Given this list of marker genes RIN2, PPARD, NDP (norrin cystine knot growth factor NDP), TSPAN3, KLF10, CES1, LEPROT (NCBI Gene Id 83080), EMC7, FASTKD1, SIK3 (SIK family kinase 3), MYO15B, SGK1, EPB41L3, APOO, PLIN2, PRKRIP1, HSD11B1, MAN2A2, CDS2, CCND1, FCGR1A, AOAH, SLC7A7, SP110, SOD2, CCL3, SERPINE1, FAH, CXCL10, CLEC4E, LYSET, LPAR1, PCK2, CYP27A1, SP140L, OAZ2, PLCL2, RDX, LAIR1, SDC2, LTA4H, FYN, CDKN1C, SLC5A3, ACAA2, SLAMF8, BCAT1, LILRB2, TMEM184C, MX2, ASAH1, TBC1D16, HDAC9, PPIF, TNFAIP6, CXCL5, MPZL1, PLA2G7, C1S, CD81, CMKLR1, EIF2B3, VAT1, DAB2, CHST15, CTSD, LPXN, RBM47, NCOA4, BCAP31, SLC16A6, DDIT4, PDCD6IP, TIMP2, SEPTIN9, MPRIP, TSEN34, DUSP6, VMP1, BTN3A3, DOCK4, HLA-DQA1, NDRG1, NUP214, FTH1, PDE4DIP, FBXL5, HK2, TSC22D1, ANXA5, FPR1, ZFYVE16, CCL18, EEF1AKMT3, DECR1, GPNMB, AKR1C1 (NCBI Gene Id 9418), CD14, ME1, CD47, CXCL9, VSIG4, SC5D, SLC29A3, PDIA5, IL1B, TFEB, ACP5, SCCPDH, ADAM28, TLE4, CD9, VWA5A, MT2A (NCBI Gene Id 4502), GCLM, SLC11A2, SCO2, SLC12A8 (solute carrier family 12 member 8), TCF7L2, SUN2, MFHAS1, PTGDS, TGM2, HBEGF, RDH11, CSTF3, ST6GAL1, YIPF6, SCD, SNTB1, MDM1, SLC36A1, STAT1, GRPEL1, CRTAM, EMC2, ITGAL, ITPR1, KCNMA1, RGCC, MYD88, ZNF395, GM2A, RARRES1, ARFGAP3, PTGER2, CTSL, NDUFS2, ELOA, SLC2A3 (solute carrier family 2 member 3), PRDX1, APOC1, MT1F, ANOS1, RGL1, ENTPD1, IRAG2, FKBP4, CNPY3, DNTTIP2, DHCR24 (NCBI Gene Id 9800), HEXB, RNASET2, METTL9, HDDC2, TNS3, TBC1D1 (TBC1 domain family member 1), IDO1, S100A9, SLC3A2 (NCBI Gene Id 6520), STK17A, GNA12, SEC22B, RHOQ, PECAM1, ABCC3, DAD1, CHI3L1, ZNF804A, CLEC5A, EREG, ACAT1, HLA-DRB4, MYOF, SPTLC2, PSMB5, ATP6V0A1, CYP27B1 (cytochrome P450 family 27 subfamily B member 1), NAMPT, CTSK, RUBCNL, GSR, GTF3A, LTBP2, LHFPL2, SQSTM1, CX3CR1, PLSCR1, NQO1, GOT2 (glutamic-oxaloacetic transaminase 2), EMG1, EGR1, TLR1, GALC, S100A12, APLP2, LMO2, SELL, CFD, FBP1, TFRC, RAB20, MTX2, IQGAP2, FCN1, MSRB2, CCR1, MMP9, SPP1, GSDME, SMIM7, AKR1B1, LXN, STOM, CHPT1, CXCL1, SPHK1, AKT3, ADAMDEC1, CCDC69, ATP6V1C1, NINJ2, SLC43A3, NRIP3, NPC1, CTBS, CALHM2, TRIT1, MRPL35, MITF, ALAS1, GGH, CHPF2, CXCL3, IRAK3, PLTP, SNX10, NOTCH2 (notch receptor 2), ACP3, C1QA, NKG7, CD163, HADHA, RAP1GAP2, TM9SF4, CCL8, EIF2AK2, ALOX5, SLC1A4, PIGP, ARHGEF40, TREM1, CPD (carboxypeptidase D), UFSP2, ALDH3A2, LAMP2, AMY1A, ATP6V0E1, SLC31A1, MT1H, MT1G, CASP1, TCIRG1, NCOA1, LILRB4, KLF9, PNP, CYBB, CERT1, SLC1A3, ETS2, PID1, NARS1, FADS1, NAT1, TMX4, CNPY2, PLAAT4, CALML4, SLAMF7, CD52, NR1H3, METTL1, SCAMP2, APOE, TMEM51, PSTPIP1, FCAR, GBA1, SLC35B1, TMBIM6, DHRS4, NEDD9, DPEP2, PDXK, PLOD3, ILRUN, TCEAL9, KMO, NR4A2, ATP6V1H, IL18, ZNF706, SCARB2, PACSIN2 (NCBI Gene Id 150377), CCL2, ITPK1, DCSTAMP, IL1A, MS4A4A, CD48, MT1X (NCBI Gene Id 82523), TNK2, IFI6, TEX2, AQP9 (aquaporin 9), TUBA4A (NCBI Gene Id 93373), DMXL2, B4GALT5, HLA-E, IFITM2, SMAD3 (SMAD family member 3), FDX1 (ferredoxin 1), SLC7A11, CYP1B1, TRAF3, ATP9B, SIGIRR, C3AR1, PIR, C5AR1 (NCBI Gene Id 728), PGS1, GADD45G, PINK1, ACADVL, SDR39U1, TM6SF1, EIF2S1, PRKCB, CRIM1, MDH1, DENND3, CCR5, DNPH1, CD300A, TNIP3, PLPP3, RERE, SH3BP5, GPD2, VNN1, C3, SLC30A1, MATK, IL10, MMP2, GLA, PSMG1, CCRL2, LAMP1, ATP13A3, GNS, IGFBP7, AMPD2, RAB13 (RAB13, member RAS oncogene family), NPL, G6PC3, SGMS1, CD55, NRP1, MCTP1, PHACTR1, CD2AP (CD2 associated protein), IMPA2, DPAGT1, SPARC, ICAM2, KYNU, STS, OSBPL1A, MEF2C, BHLHE41 (NCBI Gene Id 79365), MAPRE2, LGALS3, ST3GAL1, EMILIN1, LY86, RSAD2, RER1, FYB1, AIF1, EMP1, MAFB, ACO1, CD63, LILRA2, CCL15, FERRY3 (NCBI Gene Id 57200), NLRP3 (NCBI Gene Id 9558), CPM, TPST1, here is a description of the gene set: Human Gene Set: RUTELLA_RESPONSE_TO_HGF_VS_CSF2RB_AND_IL4_UP Genes up-regulated in peripheral blood mononucleocytes by HGF compared to those regulated by CSF2RB (GM-CSF) and IL4. Several hematopoietic growth factors, including interleukin-10 (IL-10) and transforming growth factor-beta1 (TGF-beta1), promote the differentiation of tolerogenic dendritic cells (DCs). Hepatocyte growth factor (HGF) is a pleiotropic cytokine whose effects on human DC differentiation and function have not been investigated. Monocytes cultured with HGF (HGFMo) differentiated into accessory cells with DC-like morphology, released low amounts of IL-12p70 and up-regulated IL-10 both at the mRNA and at the protein level. Upon activation with HGFMo, allogeneic CD4+CD25- T cells expressed the T regulatory (Treg)-associated transcription factor FoxP3, proliferated poorly, and released high levels of IL-10. Interestingly, blockade of surface immunoglobulin-like transcript 3 (ILT3) on HGFMo or neutralization of secreted IL-10 translated into partial restoration of T-cell proliferation. Secondary stimulation of HGFMo-primed CD4+ T cells with immunogenic DCs differentiated with granulocyte-macrophage colony-stimulating factor (GM-CSF) and IL-4 from monocytes of the same donor resulted in measurable T-cell proliferation. HGFMo-primed CD4+ T cells significantly inhibited the proliferation of naive CD4+CD25- T cells in a cell-contact-dependent manner. Finally, DNA microarray analysis revealed a unique gene-expression profile of HGF-activated monocytes. Collectively, our findings point to a novel role for HGF in the regulation of monocyte/DC functions that might be exploited therapeutically. studied in species Homo sapiens from publication Rutella S, Bonanno G, Procoli A, Mariotti A, de Ritis DG, Curti A, Danese S, Pessina G, Pandolfi S, Natoni F, Di Febo A, Scambia G, Manfredini R, Salati S, Ferrari S, Pierelli L, Leone G, Lemoli RM (PMID 16527888)